Given this list of marker genes ARMCX3, SRSF5, ELAVL2, ZNF827, RHEBL1, IL1RAPL1, GLRA2, PPP2R3A, HID1, DHDDS, TP53INP2, SNTB2, LMBRD1, RPL36AL (NCBI Gene Id 93632), MOGS, RBM39, QRICH1, JADE1, OSBP, ARL1, SRP68, CASK (NCBI Gene Id 8573), RUVBL2, TCF4, EPC1, SEMA3B, CADPS, NPAS2, SLC30A5, GPR3, APLN, NEUROD2, PIM1, EML1 (NCBI Gene Id 2009), RBM26, PRELID1, ITCH, SRSF1, LRRC59, DNM3, ADCYAP1, HOXA3, DNAJB4, CLSTN3, PRDX4 (NCBI Gene Id 82852, peroxiredoxin 4), CDC42, ABTB2, HOXA11, GLA, GYS1, MGAT2, CITED1, PLEKHF1, GOSR2, SULF1, LHX5, ASXL2, GARS1, TRIB2, REEP3, HOXB5, TSPAN7, RGS1, HOXB7, PCYT1B, GTF2A1, XPNPEP1, KIF12, HMBOX1, INTS9, PRRX1, CCND1, GALE, ELF1, STAT3, UBE2B, USO1, YIPF5, KISS1, HCRTR2, SOX21, TM9SF1, MRPS18B, TRIM55, MMP14, ARFGAP3, RFTN2, PURA (purine rich element binding protein A), TYRO3, TRPC4AP, SRPRA, SEC61A1, BCL11B, PTCHD1, HNRNPH2, MANF, MAP3K13, TRIM46, PDIA4, RAB25, FKBP14, MORF4L2, NMNAT2, NKX2-2, PRR16, PPP1R10, KDELR1, SIK2, MAGEL2, RPRD2, DENND5A, PAX1, RBP5, NR4A3, ZBTB47, IRS4, E2F3, SND1, HBP1, WFIKKN2, TMEM125, RAB24 (RAB24, member RAS oncogene family), SKIDA1, RAB1A, FOXRED1, ARMCX2, EPB41, GRIA3, DUSP7, SP1, SEC24D, IL10, NHSL2, KRTCAP2 (keratinocyte associated protein 2), SYT3, SHOC1 (shortage in chiasmata 1), here is a description of the gene set: Genes having at least one occurrence of the motif NNGNTGACGTGKNNNWT in the regions spanning 4 kb centered on their transcription starting sites. This matches the XBP1 transcription factor binding site V$XBP1_01 (v7.4 TRANSFAC). species: Homo sapiens Human Gene Set: XBP1_01